The following is a description of a gene set: electronically inferred by orthology from the curated human pathway This event has been computationally inferred from an event that has been demonstrated in another species.<p>The inference is based on the homology mapping from PANTHER. Briefly, reactions for which all involved PhysicalEntities (in input, output and catalyst) have a mapped orthologue/paralogue (for complexes at least 75% of components must have a mapping) are inferred to the other species. part of: O2/CO2 exchange in erythrocytes studied in species Mus musculus Reactome Pathway: Erythrocytes take up carbon dioxide and release oxygen, and this is the list of marker genes: Car4, Slc4a1, Aqp1, Hbb-bt, Cyb5r2